Given this list of marker genes DPM2, DPM3, DPM1, here is a description of the gene set: part of: Diseases associated with glycosylation precursor biosynthesis species: Homo sapiens Reactome Pathway: Defective DPM3 causes DPM3-CDG Dolichyl-phosphate mannosyltransferase (DPM), a heterotrimeric protein embedded in the endoplasmic reticulum membrane, mediates the transfer of mannose (from cytosolic GDP-mannose) to dolichyl phosphate (DOLP) to form dolichyl-phosphate-mannose (DOLPman). The first subunit of the heterotrimer (DPM1) appears to be the actual catalyst, and the other two subunits (DPM2 and 3) appear to stabilise it. Defects in DPM3 can cause congenital disorder of glycosylation 1o (DPM3-CDG, CDG1o; MIM:612937), a multisystem disorder caused by a defect in glycoprotein biosynthesis and characterised by under-glycosylated serum glycoproteins. CDG type 1 diseases result in a wide variety of clinical features, such as defects in the nervous system development, psychomotor retardation, dysmorphic features, hypotonia, coagulation disorders, and immunodeficiency.<br><br>Four biosynthetic pathways depend on DOLPman; N-glycosylation, O-mannosylation, C-Mannosylation and GPI-anchor biosynthesis. A defect in DPM3 strongly reduces O-mannosylation of alpha-dystroglycan, explaining the clinical phenotype of muscular dystrophy and linking the congenital disorders of glycosylation with the dystroglycanopathies.